Given this list of marker genes Pigm, Pigg, Pigq, Pigz, Dpm2, Pigf, Pigh, Pigp, Pigyl, Pigc, Pigb, Pigx, Pigv, Pigw, Piga, Pign, Pigl, here is a description of the gene set: studied in species Mus musculus Synthesis of glycosylphosphatidylinositol (GPI) Mouse Gene Set: REACTOME_SYNTHESIS_OF_GLYCOSYLPHOSPHATIDYLINOSITOL_GPI